The following is a description of a gene set: CD209 (DC-SIGN) signaling Mouse Gene Set: REACTOME_CD209_DC_SIGN_SIGNALING studied in species Mus musculus, and this is the list of marker genes: Prkaca, Fyn, Rps6ka5, Icam2 (NCBI Gene Id 15896), Pak1, Hras, Rela, Pak3, Ep300, Raf1, Kras, Pak2, Lyn, Prkacb, Relb, Cd209a, Nfkb1 (nuclear factor of kappa light polypeptide gene enhancer in B cells 1, p105)